The following is a description of a gene set: Human Gene Set: GOBP_REGULATION_OF_MEIOTIC_CELL_CYCLE Any process that modulates the rate or extent of progression through the meiotic cell cycle. species: Homo sapiens, and this is the list of marker genes: MOS, CHFR, ZWINT, METTL3, RBM46, FBXO43, ASPM, NPM2, DMRT1, PSMA8, NANOS2 (NCBI Gene Id 339345), TRIP13, UBE2B (NCBI Gene Id 7320), PLCB1, CDC16, GPR3, MSX2, WNT4, FBXO5, STRA8, CDC23, SPATA22, WEE2, DUSP1, LIF, MEIOC, CDC20, ANAPC5, INSR, CNTD1, ANAPC13, OVOL1, LFNG, NPPC, ANAPC1, CDC25C, PDE3A, NPR2, ANAPC4, FZR1, CDC26, CDC25B, STK35, CDC25A, YTHDC2, PDIK1L, SIRT2, CDC27, ANAPC2, KNL1, PIWIL2, ANAPC7, OOEP, MEIOSIN, WNT5A, ANAPC10 (NCBI Gene Id 25866), PRDM9, TTK, HORMAD1, ANAPC11, RAD1, DAZL, MSX1, CALR, PKMYT1, ANAPC16, RAD51AP1, ANAPC15, MAPK15, RPS6KA2